The following is a description of a gene set: Mouse Gene Set: CUI_NK_CELL_IFNA1_RESPONSE_DN Cytokines mediate cell-cell communication in the immune system and represent important therapeutic targets. A myriad of studies have highlighted their central role in immune function, yet we lack a global view of the cellular responses of each immune cell type to each cytokine. To address this gap, the authors created the Immune Dictionary, a compendium of single-cell transcriptomic profiles of more than 17 immune cell types in response to each of 86 cytokines (>1,400 cytokine-cell type combinations) in mouse lymph nodes in vivo. A cytokine-centric view of the dictionary revealed that most cytokines induce highly cell-type-specific responses. For example, the inflammatory cytokine interleukin-1β induces distinct gene programmes in almost every cell type. A cell-type-centric view of the dictionary identified more than 66 cytokine-driven cellular polarization states across immune cell types, including previously uncharacterized states such as an interleukin-18-induced polyfunctional natural killer cell state. studied in species Mus musculus Genes negatively differentially expressed in cell type: NK cell upon treatment with cytokine: IFN-α1 in mouse lymph nodes in vivo. from publication Cui A, Huang T, Li S, Ma A, Pérez JL, Sander C, Keskin DB, Wu CJ, Fraenkel E, Hacohen N (PMID 38057668), and this is the list of marker genes: Irf2bpl, Ablim1, Gramd1a, Pik3r1, Fos, Lamtor2, H2az2, Rp9, Mettl26, Pnrc1, Efhd2, Adcy7, Abca2, Pik3r5, Crot, Gpi1, Arhgdib, Klf6, Crtc3 (CREB regulated transcription coactivator 3), Cuta, Spn, Acaa2, Clcn3, S100a10, Scd2, Nbeal2, Cd96, Tnik, Vim, Dusp1, Eef2, Zmiz1, Tnrc6b, Trbc1 (NCBI Gene Id 100125262), Akap13, Iqgap1, Jakmip1, Cd9, Sorl1, Arhgef18, Rnf130, Abr (active BCR-related gene), Uba52 (ubiquitin A-52 residue ribosomal protein fusion product 1), Rasgrp2, Qrfp, Klrb1a (killer cell lectin-like receptor subfamily B member 1A), Il16, Arrb2, Fcgr3, Zyx, Chd3, Ogt, Cyba, Usp48, Tuba1a, Nptn, Hvcn1, Rabac1, Itgb1, Rasal3, Fau, Itpr3, Rnaseh2c, Ifngr1, Cd2, Stat4, Ccl5, Bnip3l, Sytl2, Flna, Lgals1, Stard10, Tacc1, Lasp1, Bcl9l, Fth1, Lsp1, Bin1, Epc1, Klf2, Mfsd6, Ramp1, Pglyrp1, Cd7, Tspan32, Ahnak, Cxcr3, Add1, Sike1, Ndufa6, Tsc22d3, St3gal6, Scaf11, Ripor2, Twf2, Sema4a, Sptssa (NCBI Gene Id 66149), Stk10, Cd44, Txnip, Mapre2, Card19, Ctla2a, Atxn10, Eef1a1, Stk38, H2az1, Pdcd4, B4galt1, Zfp36l2, Arhgap9, Higd2a, Rac2, Tnfaip8l2, Arrdc1, Tex261, Gas7, Thy1, Anxa2, Cxxc5, Tle5, Pycard, Arl4d, Ptpn18, Antkmt, Btg2, Emb, Entrep3, Nlrc3, Septin1, Arhgap18, Gnai2, Pigp (phosphatidylinositol glycan anchor biosynthesis, class P), Ifitm10, Kif21b (kinesin family member 21B), Smad7, Rptor, Fam53b, Rap2b, Ctsd, Atp1b1, Rgs2, Hmgb2, Klrb1f (NCBI Gene Id 338509), Klrb1c, Eif3f, Pnkd, Pdgfb, Jak1, Uqcrh, Rbl2, Ccr2, Cd27, Plec, Arhgap45, Nfatc3, Gprin3, Ets1, Apbb1ip, Clk1, Il7r, Sh3kbp1, Kcnab2, Tbc1d10c, Vgll4 (vestigial like family member 4), Tm6sf1, Ccdc88c, Kmt2c, Selenoh, Commd8, Neurl3, Hmgb1, Ltb, Pbxip1, Git2, St8sia4, Rftn1, Myl12b, Sh3bgrl3, Rabgap1l, Lat2, Arl5c, Emp3, Prex1, Bin2, Pik3cd, Mindy2, Il18r1 (NCBI Gene Id 16182), Dapk2, Ucp2, Ypel3, Atrx, Prkcb, Prkacb, Capns1, Selplg, Klf13, S100a6, Smpdl3a, Pbrm1, Crip1, Mknk2, Cdkn1b, Csk, Kif13b, Larp4b, Calm2, Cdk2ap2, Fkbp3 (NCBI Gene Id 30795), S100a4, AB124611, Laptm5, Samd3, Rnf167, Lgals3, Cxcr4, Rack1, Cbl (Casitas B-lineage lymphoma), Adgre5, Acaa1a, Maf1, Rassf2, Sipa1, Ube2h, Add3, Selenop, Gpx4, Macf1, Tprg1l, Klrd1, Tyrobp, Eef1d, Msh2, Cox7a2l, Pitpnm1, Agtrap, Mxd4, Tcf7, Rhob, Hcst, Acyp1, Myo1f, Gmfg, Fosb, Eno1, Ostf1, Ptp4a3, Myh9, Ttc3, Tecpr1, Clta